Given this list of marker genes ANK3, RFX3, SMIM15, UCN2, EML5, SLC44A2, FGD6, FKBP1B, SFT2D1, UBP1, TRANK1, PPP1R10, FOXP1, FOXJ2 (forkhead box J2), PLOD1, SYNJ1, PPFIA1, MYH9, EPS15L1, ADAM22 (ADAM metallopeptidase domain 22), S1PR3, KLF4, TMEM109 (NCBI Gene Id 79073), RPGRIP1L, MAP2K1, RGS17, AMER1, TBL1XR1, LMAN2L, KITLG, UNC13C, FAM117B, SLC37A3, ZNF304, PACS1, LEF1, DAAM1, PPP1R16B, LYST, CELF3, PDE7B, JADE2, CDH13, CACNA1C, RAP1GDS1, PDGFRA, MAP7D3, ANKS1A, RALGPS1, IGF2BP3, ZMYM4, CLOCK, NAV3, HSPA1B, SLC25A27, TPPP, RRAGC, HTR2C, C14orf28, PPP1R11, STK38L, CCNE2, OSGIN2, POGZ, RELN, NECTIN1, MGAT5B, NRN1, ARID4B, TAF5, SHISA7, TPD52, RPS6KL1, TMEM255A, TANC2, DLL1, TGIF2, NUMBL, SHOC2, TMEM164, MTCL2, PEA15, SDK2, ZDHHC16, DPYSL4, KIAA1217, NPNT, TOB2, RPS6KA4, VCL, BCL2L13, RTN4RL1, SIDT2, JAKMIP1, CERS6, KCNK3, GLCE, RCAN1, MYT1, GABRA3, ACBD3, LGR4, DGKZ (diacylglycerol kinase zeta), SUCO, GPR22, DNAJC16, CUEDC1, CACNB3, LMAN1, MET, TENT5A, TMEM74 (transmembrane protein 74), MEX3C, BRINP1, PLAG1 (PLAG1 zinc finger), XYLT1, ARHGAP26, SLC4A7, ANK2 (ankyrin 2), CBX3, TASOR, GP5, LILRA1 (leukocyte immunoglobulin like receptor A1), FBXO30, CPLX2, FRMD5, VAMP2, TNRC18, MYCN, SNTB2, TSN, LHX2, MLLT1, PKP4, ZBTB9, GMFB, WASF1, ZNF551 (zinc finger protein 551), LDHA, FLOT2, ACSL4, RTL6, SCN2B, SHKBP1, SYT1, CLCN3, TRIM67, ABR, ELMOD1, ASB4, OAZ2, BMP3, GREM2, MGAT4A, PNOC, CACNA1E, BNC2, ADD2, FAM76A, NAV1, STAB2, CA7, GPR158, ZYG11B, FUT8, PLEKHH2, ARHGAP1, MPP2, SNX9, ASB1, OLIG3, SGPP1, NCEH1, SEPTIN3, AHCYL2, BRPF3, MTMR10, PPP2R3A, FUT9, ADO, CBFA2T3, GALNT7, SNX15, CTNND2, ATMIN, DNM1L, GMNC, E2F5, RDH11, MBLAC1, ZBTB20, SRPRA, CDK6, SERPINF2 (NCBI Gene Id 5345), INA, STX17, DAGLA, RAD9B, ASIC2, DCAF7, HNF4A, FGF23, PGM1, SNAI1, SATB2, DPP3, CYREN, IL6R, DIXDC1, XBP1, ADIPOR2, FOXN2, JAG1, NOTCH2, ERGIC1 (endoplasmic reticulum-golgi intermediate compartment 1), MLLT3, SEMA4B, PURB, CREB3L2, FAM167A, RRAS, AKIP1, CNOT6, FAM83A, ACSL1, CAMTA1, ZFHX4, PTGIS, TAF4B, HCN3, NOS1AP, MDM4, ZMYND11, KDM5D, XPO5, METAP1, PITPNC1, STRN3, ZNF281, ZNF644, ANKRD52, E2F3, TMEM184B, PPARGC1B, PDXK, MCIDAS, NRIP3, NOTCH1, FRA10AC1, ZDHHC17 (zinc finger DHHC-type palmitoyltransferase 17), SLC27A4, AGO4, TPCN2, GOLPH3L, SAR1A, here is a description of the gene set: studied in species Homo sapiens Human Gene Set: MIR449B_5P Genes predicted to be targets of miRBase v22 microRNA hsa-miR-449b-5p in miRDB v6.0 with MirTarget v4 prediction scores > 80 (high confidence targets). from publication Chen Y, Wang X (PMID 31504780)